The following is a description of a gene set: studied in species Homo sapiens Genes predicted to be targets of miRBase v22 microRNA hsa-miR-4725-3p in miRDB v6.0 with MirTarget v4 prediction scores > 80 (high confidence targets). from publication Chen Y, Wang X (PMID 31504780) Human Gene Set: MIR4725_3P, and this is the list of marker genes: CANT1, ZBTB20, PHACTR1, PNOC, EFNA3, RHOF, P2RY4, CERT1, KDM4A, NEUROG2 (neurogenin 2), PUM1, HOXB9, PSMF1, VWA1 (von Willebrand factor A domain containing 1), PCYOX1, CHD3, PDLIM5, UNC5B, RALY, EI24, TET3, CD177, LY6D, ATXN7L3, CNTNAP3, SPAG7 (NCBI Gene Id 9552), OSBPL7, SASH3, CNTNAP3B, VAMP2, SYP, SDC3, SLC4A7, ELAVL2, RBM26, PDXK, PAMR1, SCAMP5, YY1AP1, DAPL1 (NCBI Gene Id 92196), RUFY2, ZBTB7A, REPS2, NUCKS1, ANAPC13, SLC38A7, WDFY1, CBX4, COG6, ZNF385A, CORO2B, ARFGEF3, IFIT1B, UBE2D2, RBM14, CCDC178, XPO7, HCFC1R1, TNS1, SPRYD4, SELENOW, ZDHHC3, TMEM127, CNOT2, KIF21B, NR2F2, CCDC68, SHISA7, LMOD1, DCAF7, ZCCHC3, PARS2 (NCBI Gene Id 91517), CABP5, GSTM5, SLC6A3, DCHS2, CFAP263, PI4KB, C1QTNF7, TRMT112, ATF5, TFE3 (NCBI Gene Id 8244), QKI, PKNOX2, KSR2, CT55, TMOD2, CCDC103, ZIC3, ELK1, GPA33 (NCBI Gene Id 105371599), ABHD5, LRRTM2, FADS2, SIPA1L3, TAGLN2, HOXD13, NECTIN1, PTPN14, ZNF346, C19orf84, PREP, AK2, BCAS3, UBE2R2, ECE1, FYCO1 (FYVE and coiled-coil domain autophagy adaptor 1), SLC24A4, CSDE1, WNT9B, ADO, KDM2A, MINK1, PIK3R3, ITGA7, CD207, DMTN, TMEM43, IGFBP4, ASXL3, RTN4RL2, MEX3A, PYGB, INO80D (NCBI Gene Id 54891), ZNF703, SCNN1A, DYNLT3, PBX2 (PBX homeobox 2), GRK6, SP1, SDHC, GJB4, RNF14, TMEM69, SMARCD1, TPTE, CHP1, CXXC4, PRDM16, ATF7, SUCNR1, MKLN1, ZNF512, VTI1A, LAMB4, NUP205, MBOAT7, NRAS, THRA, AMFR, BAZ2A, GRAMD1B, TAOK3, ABCC10, TMED4, USP51, NR1I3, SAMD4B, ZNF609, CDON, PLEKHS1, BCL2L1, CTNND1, ZMYM3, ARID3B (AT-rich interaction domain 3B), CALN1, MAZ, BRWD1, LRG1, RASL10B, TTC21A, CLOCK (NCBI Gene Id 9575), S100A14, RPL15, TUB, TMEM131, ATRN, SERF2, CALU, RNF180, FANCC, FOXRED1, MFAP4, CNGB1, PIP4K2B, FKBP5, SRSF2 (NCBI Gene Id 6427), PRDM11, SPATA12, JTB, PCDH7, RAB3A, ADCY9, PPP1R18, CHRNB2, GUCA1C, MARK2 (NCBI Gene Id 2011), MECP2, IVL, CLIC5, STEAP3, MYO1E, RHOC, FCER1G, MINPP1, FNBP1L, P3R3URF-PIK3R3, PABIR1, GRAP2, SLC7A14, FKBP1A, MFN1, ARHGEF7 (NCBI Gene Id 8874, Rho guanine nucleotide exchange factor 7), CPNE5, ARSI, MAFG, RAB11FIP4, MMRN2, BRAF, GIT1, MXRA5, CNOT8, BNC2, SH3PXD2A, ZDHHC14, ARPIN, MAF, EGR3, RELL2, LINGO1, SLC22A8, BTRC, C19orf47 (chromosome 19 open reading frame 47), OSBP, MAPK1, LZTS3 (leucine zipper tumor suppressor family member 3), NAA40, MKRN2, HDAC1, DDN, MIER3, NACC2, CD209, WAS, PAF1, CSNK1G1, PATL1 (NCBI Gene Id 219988), KIAA0319, PXN (NCBI Gene Id 80229), LGR6, MBD6, GSDMA, CHRNE (cholinergic receptor nicotinic epsilon subunit), PDYN, SYT7, LIPT2, RNF39, ZNF516, TNRC6A, EP300, DPP8, CHST3, SPRY4, IER5, USB1, FZD2 (NCBI Gene Id 2535), BRPF3, RAD18, MOXD1, ZNF592, JPH3, ZBTB4, MARCKSL1, SPOCK3 (NCBI Gene Id 50859), SHISA6, KCNA1, MAPK10, IPCEF1, SEMA4G, SCRT2, HINFP, JPH4, CXCR3, PRKD3